The following is a description of a gene set: Reactome Pathway: CASP8 activity is inhibited part of: Regulation of necroptotic cell death studied in species Homo sapiens Cell death triggered by extrinsic stimuli via death receptors or toll-like receptors (e.g., TLR3, TLR4) may result in either apoptosis or regulated necrosis (necroptosis) (Holler N et al. 2000; Kalai M et al. 2002; Kaiser WJ and Offermann MK 2005; Yang P et al. 2007). Caspase-8 (CASP8) is a cysteine protease, which functions as a key mediator for determining which form of cell death will occur (Kalai M et al. 2002). The proteolytic activity of a fully processed, heterotetrameric form of CASP8 in human and rodent cells is required for proapoptotic signaling and also for a cleavage of kinases RIPK1 and RIPK3, while at the same time preventing RIPK1/RIPK3-dependent regulated necrosis (Juo P et al. 1998; Lin Y et al. 1999; Holler N et al. 2000; Hopkins-Donaldson S et al. 2000). A blockage of CASP8 activity in the presence of caspase inhibitors such as Z-VAD-FMK (pan-caspase inhibitor), endogenous FLIP(S) or viral FLIP-like protein was found to switch signaling to necrotic cell death (Thome M et al. 1997; Kalai M et al. 2002; Feoktistova M et al. 2011; Sawai H 2013)., and this is the list of marker genes: CASP8, FASLG, TNFRSF10A, TRAF2, FADD (Fas associated via death domain), TRADD, RIPK1, TNFRSF10B, TNFSF10, FAS, CFLAR